Given this list of marker genes IL2, CXCL10, CCL3, CXCL8, IL10, IL7, ACE2, AGT, IL2RA, CCL2 (NCBI Gene Id 6347), TNF, CSF3, IL1B, TMPRSS2, IL6, here is a description of the gene set: species: Homo sapiens Human Gene Set: WP_COVID19_ADVERSE_OUTCOME_PATHWAY COVID-19 adverse outcome pathway